Given this list of marker genes GDF11, AREG, CCL22, GPI, TNFSF9, CCL8, IL17F, WNT2, GREM1 (NCBI Gene Id 7947), IL36B, IL11, CCL28, LEFTY1, WNT9A, WNT3A, EPO, GDF5, GPR15LG, ALKAL2, IL12A, WNT6, CCL23, CXCL9 (C-X-C motif chemokine ligand 9), INHBB, CCL4, OSM, CX3CL1, IL36A, WNT10A, IFNW1, FAM3D, TSLP, BMP15, FAM3C, IL37, KITLG, CCL3L3, BMP8A, IL20, IFNA21, TIMP1, IL3, PF4V1, MSMP, CSF3, WNT8A, INHBC, BMP5, IL6, IL33, CCL25, IFNA17 (interferon alpha 17), C17orf99, CCL17, SPP1, TNFSF15, CCL15, IFNA6, IFNA5, IL2, CKLF, CTF1, CCL19, PF4, IL17C, IL4, CMTM8, TNFSF8, TNFSF11, GDF10, IFNB1, TNF, IFNG, VSTM1, BMP10, TNFSF10, EDA, GH1, IFNK, XCL1, CSF1, C1QTNF4, EDN1, TNFSF18, GDF15, EBI3, IL31, IL22, NAMPT, IL15, CMTM2, IL7, WNT10B, TGFB2, MIF, LEFTY2, CXCL11, IL16, CXCL8, TNFRSF11B, WNT5B, WNT16, CCL7, HMGB1, IL18, WNT1, FASLG, GDF9, IL1B (NCBI Gene Id 3553), IFNL1, C5, IL12B, CXCL5, AIMP1, INHBA, LTA, MSTN, IL10, IL9, WNT7A, WNT4, TGFB1, BMP2, WNT3, FLT3LG, IFNL4, CCL16, SLURP1, IL1A, BMP1, IFNL2, GDF2, IFNL3, SECTM1, IL27, CXCL16, CLCF1, IL24, CCL27, IL23A, CCL21, TNFSF12, BMP7, TNFSF14, IL13, SCGB3A1 (NCBI Gene Id 92304), XCL2, CXCL1, WNT7B, CMTM1, WNT9B, TAFA5, CXCL3, VEGFA, TNFSF13B, GRN, THNSL2, GREM2, IL19, CXCL2, LTB, CMTM3, CNTF, IL17B, CCL18, CSF2, GDF3, IFNA7, IFNA4, IFNE, CCL4L2, SCG2, IL1RN, CXCL13, INHA, LIF, CXCL10 (C-X-C motif chemokine ligand 10), ADIPOQ, CER1, CCL13, CCL11, GDF6, PPBP, IL17A, IL5, BMP3, CCL1, CCL14, THPO, IFNA1, ALKAL1, IL21, IL32, NDP, CCL20, CCL5, CXCL6, IFNA8, IL36RN, CD40LG, TNFSF13, IL1F10, IFNA16, CXCL12, IL25, BMP4, IL17D, INHBE (NCBI Gene Id 83729), CCL2, WNT2B, WNT8B, WNT11 (Wnt family member 11), IFNA10, CCL3 (NCBI Gene Id 6348), NRG1, TGFB3, FAM3B, CMTM7, CXCL14, CCL24, TNFSF4, GDF7, GDF1, IL36G, NODAL, IL34, IFNA2, CRLF1, WNT5A, BMP6, IL26 (NCBI Gene Id 55801), CCL26, FGF2, BMP8B, CMTM5, IFNA14, here is a description of the gene set: studied in species Homo sapiens The activity of a soluble extracellular gene product that interacts with a receptor to effect a change in the activity of the receptor to control the survival, growth, differentiation and effector function of tissues and cells. Human Gene Set: GOMF_CYTOKINE_ACTIVITY